The following is a description of a gene set: species: Homo sapiens Human Gene Set: MIR643 from publication Chen Y, Wang X (PMID 31504780) Genes predicted to be targets of miRBase v22 microRNA hsa-miR-643 in miRDB v6.0 with MirTarget v4 prediction scores > 80 (high confidence targets)., and this is the list of marker genes: TERF1, HOOK3, ELAVL4, PDE1C (phosphodiesterase 1C), RAB18, GRID1, PRKD3, DNAJC28, TBR1, SNHG32, GATA6, PDZD7, LHX8, PLXDC2, C5orf24, ZNF330, COG5, CLK2, F5, CYREN, CCDC138, STIL, KALRN, CTBP2, ZNF449, CDC37L1, CDKL3, SOHLH2, JADE2 (NCBI Gene Id 23338), RAD54B, BAG2, ANK3, COL13A1, MAP2K6, SLC36A4, LYRM7, EREG, CD2AP, LONRF2, BMP8B, ACKR4, TRIM61, FSBP, KIAA1328, ANKS1B, PIGF, RAB27B, TRMT9B (tRNA methyltransferase 9B (putative)), CIT (citron rho-interacting serine/threonine kinase), RB1, RAB33A, SPTY2D1, WDR33, ADGRL2, TXNDC9, MSRB3 (NCBI Gene Id 253827), CACNA1B, KCNJ15, MYH11, CDK15, TAFA2, USP3, PAFAH1B2, ZNF569